Given this list of marker genes EFCAB2, NAV1, TBL1XR1, PALB2, NR2F1, AKIRIN1, STX17, SEL1L, C5orf47, NUCB1, OTX1 (NCBI Gene Id 93105), TRIO, BICC1, IL20RA, TNFRSF1A, PIAS1, MICU3, RAB21, CERT1, TAF4B, ACTN4, MTMR12, RALGAPB, HECTD2, CLSPN, ANTXR1, PPP1R21 (NCBI Gene Id 129285), BLOC1S6, TNPO2, MCF2, THBD, SSRP1, P2RY14 (NCBI Gene Id 9934), CORO1A, ENPP3, CREB5, FOXJ3, CLMN, CHMP7, RWDD4, NRXN1, TANK, PHF6, CABLES1, SH2B3, TFPI, JPH4, PDCD6IP, DTD1, PALM2AKAP2, KLF7, ZNF814, URM1, ADAM12, PADI2, ANKRD61, EIF3A, POU2AF1, CALCRL, SIAH1, STIM2, BPNT1, TTC7A, C1QL3, SLC30A5, FCAMR, FGD4, NR4A3, TNIK, USP16, AOPEP, GLUD1, GHITM, HSPA13, SERINC3, ZNF587B, GARRE1, MGP, G2E3, KRT5, HELQ, PPP2CA, RNF212B (NCBI Gene Id 378704), CHRDL1, GRPEL2, POMT2, SRSF1, SLC12A3, MFSD11, XIAP, STUM, PRR15, SLC39A9, GPA33 (NCBI Gene Id 105371599), STARD7, XPNPEP3, WDR5, NMT2, PSMD9, PRPS2, ZFR, RPF2, SKIDA1, TNFSF4, ENTREP2, CCDC141, SLC7A10, PDE4DIP, POU3F3, ZBTB8B, FAP, OTP, PPM1H, PTPMT1, FRAT2, CEP57L1, NXPH1, FUT1 (fucosyltransferase 1 (H blood group)), KIF11, CHD1, LRTM2, SPOCK1, CNOT4, TRIM9, SCG2, PSME3, TCAF1, EID1, ICMT, UBR2, METTL21A, RTF1, RGS6, AMD1, CTNNA3, ME2, TRAF6, PLXDC2, CNTNAP5, ARHGAP19, CALU (NCBI Gene Id 813), RNF2, OGT, CEP170, ARRB2, GOPC, GPANK1, TP53INP2, PSMF1, GABRA5, UFC1, PAFAH1B1, TRPC5, SHCBP1, CCND2, ARHGEF12, SYNGAP1, ADCY1 (adenylate cyclase 1), FAM199X, PRPH2, SHTN1, BOC, CPD, CHERP, PGC, EPHA3, FGF4, SNX7, CRTAP, CFAP221, IKZF2, ZNF827, PRTG, GMFB, IL10RA, HSD17B12, DENND2D, ARHGEF3, PIGA, RWDD3, DCBLD2, PVALB, ELK4, KLF2 (NCBI Gene Id 51713), IRAG1, H3-3A, DPP10, ZSWIM6, PITPNB, AJAP1, TIPRL, ANKRD28 (ankyrin repeat domain 28), CTDSPL2, SUDS3, NEXMIF, CUL4A, ADCY2, PPP1R12A, ATOH8, SLC35A3, TBX15, CPSF2, RAPGEF4, P4HA1, SLC25A27, NEXN (NCBI Gene Id 91624), COPS8, MED13L, PIGN, ELMOD1, ETNK1, LYRM9, BBX, POU3F1, ZMYM4, RNASEL, XRCC5, DNM1, TP53INP1, NEGR1 (NCBI Gene Id 257194), UNKL, DTNA, FSTL1 (follistatin like 1), SACS, NPAS3, SREK1, RPAP2, ADTRP, PCGF2, ZBTB34, IL1A, ESF1, PCGF5, CEMIP2, UNC119B, TLN2, ISCA1, TNFRSF10B, GPR62, AGTR2, DPY30, UBQLN1, SPTSSB, DCAF12L1, NKRF, CFAP47, ARK2N, G3BP1, ZNRF2, MKX, A2M, IBTK (NCBI Gene Id 25998), PDIK1L, GLTP, PDLIM4, SLC30A7, PAQR6, PTER, GALNT13, CLEC12A, SHKBP1, ADH5, ZBTB20, CDK6, CERS6, FIP1L1, LIN54, TRIM60, KDM2B, HBEGF, KCTD2, ICE2, ELOVL6, FOXO1, DNAJC15, FZD3, OLIG3, SPATA8, ZNF776, SLC25A33, MORC3, ANKLE2, ELAVL4, ASIC1, GRM5, BDH2 (3-hydroxybutyrate dehydrogenase 2), NDUFB6, CHRAC1, here is a description of the gene set: Genes predicted to be targets of miRBase v22 microRNA hsa-miR-9902 in miRDB v6.0 with MirTarget v4 prediction scores > 80 (high confidence targets). species: Homo sapiens Human Gene Set: MIR9902 from publication Chen Y, Wang X (PMID 31504780)